The following is a description of a gene set: Genes predicted to be targets of miRBase v22 microRNA mmu_miR_7088_3p in miRDB v6.0 with MirTarget v4 prediction scores > 80 (high confidence targets). studied in species Mus musculus Mouse Gene Set: MIR_7088_3P from publication Chen Y, Wang X (PMID 31504780), and this is the list of marker genes: Scn2a, Foxn1 (forkhead box N1), Tmem167, Igdcc3, Mosmo, Extl3, Cdk12, Fam220a, Crybg3, Lmo2, Nxph1, Ppp1ca, 1600012H06Rik, Bmpr2, Rhoq, Emc7, Enc1, Tinag, Tbc1d23, Coq3, Cxcr5, Bcat1 (NCBI Gene Id 12035), Macf1, Diaph2, Esr2, Ctsl, Wipf3, Ptpre, Zdhhc6 (NCBI Gene Id 98138), Wdr81, Pabpc4, Rap1gap2, Dlg5 (NCBI Gene Id 97944), Zfp263, Brap, Rabggtb, Wdr44, Krtap6-7, Zfp654, Ptpro, Stc1, Csf1, Tardbp, Ogdh, Zpbp2, Mknk1, Arid1b, H2az1, Actr2, Kpna3, Fgf12, Xkr4, Hp1bp3, Noto, Fabp3, Tut4, Ppp1r1c, Arfgef1, Tsga10, Scn1a, Zfp30, Ankrd42, Klhl29, Tmem209, Dcdc2a, Igdcc4, Dynlt5, Selenoh, Rwdd4a (RWD domain containing 4A), Plxnb2, Zfhx3, Pxmp2, Rala, Gabra3, Atf1, Lin7a, Crem, Kcne4, A1bg, Dennd1b